Given this list of marker genes CSNK2A1, BMAL1, CDK5, CSNK2B, CLOCK, here is a description of the gene set: Phosphorylation and nuclear translocation of BMAL1 (ARNTL) and CLOCK Human Gene Set: REACTOME_PHOSPHORYLATION_AND_NUCLEAR_TRANSLOCATION_OF_BMAL1_ARNTL_AND_CLOCK species: Homo sapiens